Given this list of marker genes Cdh1, Arhgap35, Gnai3, Akt1, Rgs14, Gapvd1, Gnao1, Pin1rt1, Tubb5, Mex3b, Gnb5, Gnai1, Camk2a, Nkiras1, Plxnb1, Nkiras2, Fmnl1, Pin1, Plcd1, Fmnl3, here is a description of the gene set: Mouse Gene Set: GOMF_GTPASE_ACTIVATING_PROTEIN_BINDING Binding to a GTPase activating protein. species: Mus musculus